The following is a description of a gene set: Comprehensive identification of all functional elements encoded in the human genome is a fundamental need in biomedical research. Here, we present a comparative analysis of the human, mouse, rat and dog genomes to create a systematic catalogue of common regulatory motifs in promoters and 3' untranslated regions (3' UTRs). The promoter analysis yields 174 candidate motifs, including most previously known transcription-factor binding sites and 105 new motifs. The 3'-UTR analysis yields 106 motifs likely to be involved in post-transcriptional regulation. Nearly one-half are associated with microRNAs (miRNAs), leading to the discovery of many new miRNA genes and their likely target genes. Our results suggest that previous estimates of the number of human miRNA genes were low, and that miRNAs regulate at least 20% of human genes. The overall results provide a systematic view of gene regulation in the human, which will be refined as additional mammalian genomes become available. from publication Xie X, Lu J, Kulbokas EJ, Golub TR, Mootha V, Lindblad-Toh K, Lander ES, Kellis M (PMID 15735639) Genes having at least one occurrence of the highly conserved motif M55 TGGAAA in the regions spanning 4 kb centered on their transcription starting sites. This matches the NFAT, NFATC transcription factor binding site V$NFAT_Q4_01 (v7.4 TRANSFAC). Human Gene Set: TGGAAA_NFAT_Q4_01 studied in species Homo sapiens, and this is the list of marker genes: BMP2K, SMAD5, MRPL37, MYL3, ZMYND8, UBE2U, DNAH12, DAB1, TIMM9, FASTKD2, BAAT, ANGPTL2, RAB6A, ANKHD1-EIF4EBP3, RCAN2, UTP18, C3orf49, LYG2, LIF, RNF43, TSPAN2, LRATD2, PIM2, CAMKV, CORT, C6orf62, TLX3, PLEKHN1, NEDD4L, C8orf34 (chromosome 8 open reading frame 34), GLS, CRAT, HOXD3 (NCBI Gene Id 3232), SLC25A13, STARD13 (NCBI Gene Id 90627), HS6ST2, SKP2, ARID1B, ARRDC4, TJP2, PPARGC1A, SPRED1, FERD3L, PITPNC1 (phosphatidylinositol transfer protein cytoplasmic 1), GAS2, ZBTB5, MTF1, DAAM2, KMT2D, ENPP2, SPRY2, AMD1, IL1RN, WBP2NL, GPR22, GCNT2, STIP1, QTRT2, DHX40, DIAPH1, ATXN1, CDK11B, SFTPD, ETV5, DIS3L2, EPN1, BZW2, VAX1, WNK4, CITED2, LAP3, PPP2R3A, EFHD1, SOX14, MXI1, S1PR2, CFAP53, LDHAL6B, AKR1B1, DYNLL1 (dynein light chain LC8-type 1), FLVCR2, LRRTM4, IL2, SEPTIN9, EDA, TNFSF10, PTPRZ1, STAG1, HGF, SLITRK3, NHERF1, TMEM117, ANGPT1 (NCBI Gene Id 284), TNXB, HOXD8, IL7R, UBE2O, AMBN, TYR, GABRR1, TOB2, IFNG, CREM, MLIP, VAMP3, ZFAND3, MGAT4B, HS3ST3B1, KCNN2, FCRL2, GPR107 (G protein-coupled receptor 107), KCNJ2, CCDC191, LURAP1L, PPP1R1B, DAW1, KRT8P41, RPL23A, TMPRSS2, LTBP2, ADD3, GPR158, SERPINI2, BNC2, NSUN4, ASPH, MBNL2, HDAC6, LAG3, SOX2, RBMX, GASAL1, ADGRV1, LIMS1, SAG, ADAM9, ADORA1, TLL1, MTX1, SVIL, TMEM108, ESPN, RUNX1T1, FGF8, PHF21A, VEGFA, PPP1R10, VN1R3, TUBA1A, ANKRD28, MXRA8, RBM14, MRC2, MRPL28, POU2F3, NNAT, OTX1, RNF6 (NCBI Gene Id 6049), ISYNA1, FARS2, PHF6, SLITRK1, MRGPRF, SH2D2A, VPS37B, WNT5A, HSD17B12, KIRREL2, TSC22D3, CDH5, PAX3, POU2AF1, ZNF431, FAM241A, EOMES, ARCN1, NUAK2, CD40LG, DDX3Y, TFAP2D, DDR2, PPARA, IL4, ACMSD, TCEAL7, MARCHF5, ATP6V1G1, FAM107B, SRPX, NTF3, ZBTB10, GRWD1, MIR137HG, DTNA, ZNF532, PDLIM3, SSBP2, NPEPPS, SLC16A11, JAG1, HOXA5, RUNDC1, ATP1B4, ADAM12, ZNF502, CEP120, APOD, NFATC2, SREK1, EPC1, RELCH, TNFRSF11B (NCBI Gene Id 4982), TRDMT1, IKZF2, CFAP47, EBF2, MTBP, MYO19, PRKAG2, SPATA31H1, RWDD3, GREB1, XPOT, RAB11A, GPR42, GDNF, ANKRD42, CAB39L, MOBP, RASGEF1A, AQP4-AS1, SMPDL3A, GRM3, KRTAP17-1 (NCBI Gene Id 83902), MCF2, ADAMTSL3, NCKAP5, USP32 (NCBI Gene Id 84669), MAP3K8, PPP2R5D, NFATC4, ARHGEF12, FCRLA, PCF11, ARHGAP29, ZC3H10, GDA, IGF1, UBQLNL, PDK2, HYAL3, EIF4H, CALHM2, EYA1, PDK3, CLEC1A, ENPP3, RASGRF2 (NCBI Gene Id 89993), PAX6, LMO3, SOAT1, SMPD3, EIF3D, RACGAP1, WWP2, SIK2 (salt inducible kinase 2), FSTL5, HOXA11, RTL10 (NCBI Gene Id 79680), S100PBP, SPP1, LLCFC1, NMNAT2, HPX, A1CF, ZEB2, HCAR1, TAC1, EIF3J, ZNF711, TCF4, KCND3, TPI1, SRSF6, RGS1, PELI2, ZIC1, PITX3, RARB, DCLK1, DICER1, PIGB, LAMB3, NSG2, CCN1, ZIC4, EGFL6, AGO3, USPL1, GDPD5, AP1G1, LIX1L, GAS7, PKP4, UBE2E1, GFOD1, IL23A, NFIA, HHATL, PSMA1, NAA50, DEF6, RPA3, ZNF354C, BTBD10, UCK2, MME, MIR17HG, ZNF563, MAPK10, WNT1, CCNI, TECTA, SMC1A, ERBB3, RALYL, FUZ, ELK3, CCDC14, SRCAP, OSCAR, EHMT2, KANK4, ABRA, TFAP4, CLCN3, PCDH20, NUP210L, ZFAT, RCOR1, MRTFA, ABR, EMILIN3, CEP41, FLJ40288, SERPINC1 (NCBI Gene Id 462), SFPQ, ELMOD1, FAM170A (NCBI Gene Id 340069), TRMT9B, CNIH1, MAB21L2, XPNPEP1, SPINT1, RBFOX2, F9, CARTPT, STOML2, SLC6A12, BARHL1, TASOR, PRMT5, CPE, HNRNPC, DAAM1, FAM120C, TNFRSF19, COLEC12, BEND7, GDF10, ANKRD36B, IDH3B, TSPAN5, CNOT8, ANKHD1, SDHC, CNTNAP2, SMTNL2, CRISP1, TRIM46, PSMB5, TNS1, CPA2, RIPOR2, GADD45A, SOS1, PACSIN3, MRPS6, ARL6IP5, HNRNPH3, FLRT3, SCUBE3, DCUN1D4, MAP4K2, DCDC1, EN1, CHN1, SOX10, CCDC80, TM2D2, GNAO1, FZD7, SDC4, CDC5L, DIPK2B, FGF10, RBM39, ENSG00000291228, EIF4G1, EPYC, FXYD6, HNF1B, SIX3, DZANK1, RESF1, NKX2-2, BDNF, BTBD9, R3HDM2, IL2RG, RIT1, ATP2B1, ACE2, AP3D1, IL6, LRRC75A, JADE1, NCL, IL17RB, ZNF143, FGF12, BICDL1, RARA, PLAGL2, SHANK2, RREB1, NUMB, CCDC6, VSNL1, SRFBP1, CNTF, CD86, BCL2L14, ADAMTS2, KRT14, MECOM, SORBS3, HOXC4, SV2A, DCLK2, ZNF710, KIF21A, TAFA1, ANKRD20A19P, ATG2B, NFAT5, RHEBL1 (NCBI Gene Id 121268), PAQR5, DMP1, KLHL4, RUSC1-AS1, TIAM1, OMA1, NREP, ZNF521, CCDC148, CCDC3, HS1BP3, REPIN1, TNFSF11, EVA1A, NIM1K, TREX1, HNRNPF, CCNC, PRCC, CORO1C, FLNC, KLF12, NOL4L, XPNPEP2, LINC00671, TNFAIP8, CDC42EP3, C16orf74, TAL1, NR3C2, PER2, C22orf31, ACO1, IFT20, WDR5B, MAP2K3, FAM110D, MYF5, PDP1, FSTL1, PLAC1, PNOC, SCN3A, RRBP1, TSHZ2, NAA38, IQCB1, GABPB2 (NCBI Gene Id 126626), WNK1, CFAP161, CACNB1, CTLA4, GPHB5, HOXC11, LEP, CRK, PRKD2, TSSK3, PFDN1, LINC02363, HOXB7, POU3F4, NSD2, LYZL4, RAPGEF6, GATA3, SEMA4C, DNAJB7, TACC2, ACYP2, CREB5, KCNH5, STXBP1, NDUFS4, CILP, ZNF445, IMPA2, EGF, RNF128, HOXA1, ST8SIA4, TCF12, HOXB1, CYFIP2, HSD3B7, NR1D1, FAM117A (NCBI Gene Id 81558), JDP2, SOBP, NONO, CSRP3, RABL6, VWA1, ARMCX6, NDRG2 (NDRG family member 2), TAC4, KLF8, GMIP, LRRN4CL, LGSN, TADA2A, SLK, HCFC1R1, CCDC91, COPS3, PRKACA, TMBIM6, EAF2, NOTUM, RORA, RPL41, WRAP53, CYB5D1 (NCBI Gene Id 124637), SLC35A2, NCDN, RAB30, C3orf62, HSPH1, SOX11, NDUFB9, NRIP2, HAO2 (NCBI Gene Id 51544), ABCD2, STRIP1, CIMIP6, CLEC11A, TP53BP1, HOXA13, ABHD5, RASGRP3, HOXB2, C4orf36, OPCML, ANGPTL7, SLC43A2 (NCBI Gene Id 124935), CCDC18, LSAMP, FOXD3, PLCL1, CNIH4, OLFML3, ALS2CL, FHDC1, DONSON, SORT1, CAD, TBX5, ZFAND5, SMARCA2, IL17B, UBL3, DLL4, GKN2, ABLIM2, GCAT, LINC00303, NRGN (neurogranin), UCN3, SNX15, DHX37, ZBTB18, MDH1, NIN, RCAN1, CACNA1C, TRERF1, ZZEF1, CSPG4, ENPP1, HIVEP1, SLC44A3, INSRR, DCUN1D3, ETNK2, NRG1, EMP1, HAUS3, MEIOB, LINC00305, KRTCAP2, HOXA9, FTH1, BTG1, GPR135, RUNX1, CAVIN1, MEPCE, RNF19A, VCAN, PCDHA11, ITGA2, ESR1, CFAP57, MAGIX (MAGI family member, X-linked), SYNRG, PID1, PODN, CACNB2, TRIT1, ACKR4, ITGB1BP2, NEDD4, ZNF282, CHD2, CHCHD7, VPS11, LMO2, IL16, TBL1X, FBXL14, GAD1, DOCK8-AS1, CALM1, SACM1L, LDB2, VIT, GATA6, BMP2, STN1, PRSS12, NR5A2, SOHLH2, DDC, MAPK6, MIER3, BMP5, KCNJ10, PCDHA13, GAPT, PCSK7, GABRE (gamma-aminobutyric acid type A receptor subunit epsilon), FXYD2, GALNT7, IP6K2, TRIB2, ZNF593, TAFAZZIN, GABRB3, MAP4K4, LRP6, PDGFB, GLS2, MRPS18B (mitochondrial ribosomal protein S18B), PRKCH, PPM1K, S100A8 (NCBI Gene Id 6279), HTRA4 (NCBI Gene Id 203100), CISH, ANXA10, SOX3, PCDHGC3, CAPN6, TMEM164, UBE2B, NOS1, LOX (NCBI Gene Id 4015), MTIF2, PDE1B, WASL (NCBI Gene Id 8976), KCNA5, ADAMTS4, KCNJ8, LINC00898, C12orf50 (NCBI Gene Id 160419), DYNLT5, DOC2B, GTF2E2, CMSS1, SH3KBP1, DCHS2, JMJD1C, MAN1A2, STX16, PLOD2, GNAQ, SLC25A4, TEC, CPNE1, CASK, COL16A1, SLC39A7, APOM, GIGYF2, PIGN, CSAD, MTSS1, JADE2, RBM12B, AGTR2, GTPBP1, EIF1, PRELP, ABRAXAS2 (NCBI Gene Id 96567), IL12B, GPSM2, DIO2, PPM1D, BMI1, ZDHHC18, ZNFX1, NFKBID, MECP2, CADM2, TNFAIP1 (TNF alpha induced protein 1), STAC2, ZIC5, MCC, POU4F3, IFT22, OTUD5, PYGB, WFIKKN2, NAPG, GPR173, NDP, DCN, PSME3IP1, LMOD1, SRPK2, RABGAP1L, CHRNB3, SERPINH1, ZNF436, USP12, CNTD1, ALG6, VCP, SLC30A7, SLC7A8, LHX1, PHACTR3, HDDC3, PHTF1, KCNQ5, HAS2, PABIR3, TBL1Y, YWHAQ, RASSF2, ZNF654, SEMA7A, LGALS1, OFCC1, ZNF547, MAP7, KIAA0825, SLC17A6, ID4, SENP1, ERRFI1, UBALD2, SERPIND1, PPP2R1B, AQP2, ZFHX3, XBP1, WDR81, ADCY2, CDKN1A, PLPPR1, PICALM, NEURL1, BOK, GYPC, COL1A2, POGK, SNCAIP, BSN, PRPF38B, RTL3, SPAG9, VIM, CHM, UGT1A6, XYLT2, SIAE, PRRT1, GPER1, FCHSD1, CRTAC1, LINC00649, NFATC1, MAB21L3, HNF4G, SATB2, WIPF1, LIMK2, ATP1A2, PNLIP, GAL3ST3, CRIPT, ATP1B1 (NCBI Gene Id 481), MYO1E, RBMS2, SEPHS2, BMX, C1RL, ST6GALNAC3, RAB8B, PDLIM5, ATP2B4, EMX1, FBXL19-AS1, XPO1, KCNA1, ELAVL3, PDE4B, STAT3, CLVS1, NDUFC1, SFMBT1, NALF2, ZNF296, KIRREL3, KCNJ13, ZNF800, CDH6, EDNRA, COL12A1, SNX25, TINF2 (NCBI Gene Id 26277), REST, CTBS, TGFB2, KYNU, PUM3, NR4A1, MED26, LRRTM3, TBX3, FAP, DLG2, HOXA10, MMP14, DBN1, NUDT2, SEMA3A, ESRRB, KLF7, CNTN5, HOXD10, CHDH, RASGRP4 (RAS guanyl releasing protein 4), SRC, CALCR, IL9, AEBP2, KCNQ4, GNAS, NDST4, TNPO1, NR4A2, CD79B, YAP1, GNGT2, TRIM25, TGIF1, VEGFB, CRCT1 (NCBI Gene Id 54544), C21orf91, NEK10, CTTNBP2NL, SLA, DSG3, DNHD1, SPATS2, IL1RAPL1, SBF2 (NCBI Gene Id 81846), CCL5, KCNJ14, PSMA8, ILDR1, IL6ST, PLCB1, NOB1, FHL3, WARS1, NR4A3, DOCK3, DNMT3B, C1S, CTHRC1, IRS2, TWIST1, CYP26B1, PYM1, TECR, REEP6, GLRA2, TSEN34, EBNA1BP2, NAV3, ARRDC3, GAP43, SCAMP1, SPMIP6, PEX1, ZMYM4, AMPH, CD74, PAGE4, DEPDC7, FABP2, NMB, GDAP1, PIGW, ZMIZ1, WNT9B, NGF, CELF4, HDAC4, SLC16A6, ASPN, SHOX2, YARS1, VAMP8, DDX17, DLX1, TRPS1, RALY, HEPACAM, BPIFA1, MLF1 (NCBI Gene Id 4291), FBL, ITGB8, RPS10, EDC4 (enhancer of mRNA decapping 4), LRP2BP, SERPINB10 (NCBI Gene Id 5273), AGBL1, SFRP4, ECEL1, ZNF430, SLC9A7 (NCBI Gene Id 84679), KMT2C, KLF5, NFIB, GIMAP1, SGCD, HOXA2, ACSS1, CLCA3P, ACLY, VPS13B, LRRTM1, ZBTB32, STX4, TMEM97, CDK2AP1, LSM6, FXR2, ZNF138, ESYT2, SYTL4, C6orf47, LOXL1, IL22, SOX21, ARHGAP18, LRP1B, STARD4, TBC1D8B, GPANK1, DTX3, PHEX, KLHL9 (NCBI Gene Id 55958), KATNA1, FCAMR, NT5C2, PPM1B, OSTN, ZNF396, RTKN, SLC16A1, PIGF, ACKR3, CD72, FFAR2, SELENOI, TMPRSS11F, IFRD1, RBM48, ATP6V1A, IL25, MYO1C (myosin IC), ABL1, FFAR3, TTLL6, LRRC2, RCC2, FHL5, KLF14, PPP2R5E, NSRP1, C1QL1, TRARG1, GRK5, SENP8 (NCBI Gene Id 123228), ID2, DLGAP4, ZNF768, LRRFIP1, DNAJA1, NXF4, TMEM187, TMEM9B (TMEM9 domain family member B), CCDC140, HAND2, STK26, MGP, PPFIA2, FN1, TRIM8, PTK7, GRIN1, SCN2B, ATXN10, POU4F1, AQP4, PDE4D, ATXN7L1, DPYSL2, APMAP, FST, FCER1G, KRIT1, ARHGEF2, CREBZF, ASIC2, NUP155, SERTAD4, CDKL2, BEX3, UBE2H, ARHGEF25, FGF6, ADM, DES, DPH1, RASL12, ADAMTS14, C17orf50, HAND1, INS, ITIH3, HSPA4L, DEAF1, GPR85, IQGAP3, TAGAP, WWOX (WW domain containing oxidoreductase), SEMA6D, TNF, CTSK, PVALB, SLC38A2, KIAA1549L, MEF2C, PRDM1, CALD1, NFKBIA, BCL11A, C9orf72, PRG4, JPT2, UNC5C, GUCY1B1, SPAG6, KRT17, ATP2C1, MIR22HG, NAP1L5, FUT7, IGFBP7, AOC2, CUL3, PTGER1, BMP6, STC1, COX4I2, C1orf21, TEAD1, DPF2, ELF5, SLN, HOXA4, MMP3, ABCB7, HS6ST3, ARHGAP8, FGF14 (NCBI Gene Id 317685), RNF220, KERA, PTPRA, RBMS3, COPZ1, STX7, POFUT1, ENSG00000204117, PCDH10, FGF16, PCSK6, AIG1, DPF3, CHST11, CPEB3, HESX1, SMC2, HECTD2, CPLANE2, ALYREF, PHKA1, CALB1, RFTN2, KLF11, ATP1B3, SEPTIN7, ANAPC11, IRX5, RNF152, KIAA0586, PTGER2, NFIL3 (NCBI Gene Id 4783), CDK6 (cyclin dependent kinase 6), CYP2D6, C1QTNF3, GLA, KBTBD12, HYAL2, THBS3, NECTIN1, SPP2, HMGA2, CTAGE4, TENT5A, RARG, ITGA7, IL23R, HTR7, AP4S1, COL2A1, PCBP2, ICAM1, TNFRSF8, ZFP36L1, EHD4, MEIS1, RNF133, SP1, DAB2 (NCBI Gene Id 1601), SCG2, AJUBA, ATP5MK, SMARCE1, FOS, ACAP1, SNX12, EGFLAM, NRN1L, HMGCR, EXD2, RELA, ESRRG, PGRMC2, TGFB3, PCDH12, MARCKSL1, PGAM1, MYH1, GSN, ITPR1, CACNG2, CSNK2B, POGZ, C8orf82, COTL1, ST8SIA1, ZNF277, HIGD1B, CPEB4, HIGD1A, FNDC9, FOXP3, MFSD14A, SGK1, ELAVL4, DGKG, TSHB, GPR150, MSMB, SLC7A1, TYMP, PTP4A2, NOG, OPHN1, ARL5A, THOC6, SOX5, CLDN17, TFE3, OMD, RASAL2, SAYSD1, RETN, OGT, PTOV1, BHLHE40, HAPLN1, NF1, PIK3IP1, TNFRSF1A, LTC4S, MAGEH1, NPAS2, MAPK4, LDHB, TBX20, ARMCX4, SOX9, LGALSL, S100A10, CFAP70, GRB10, MTX2, SYNC, MAFF, AIFM1, OVOL1, TFDP2 (NCBI Gene Id 7029), GLDN, PRF1, TMEM125, PLXNB1, MAN1C1, PPP4R4, SULF1, PAX1, CMTM6, SYT4, FUT11, MYO9A, CNIH2 (NCBI Gene Id 254263), SLITRK5, DCTN4, PDXDC2P-NPIPB14P, VGLL3, SDCBP, DNTT, TEX15, PCDHA6, H2BC21, MTMR11, SSTR5, VAC14, PLEC, IL5 (interleukin 5), BRINP3, HSD11B1, ELMO1, CASKIN2, SMURF2, NTNG2, NKAIN3, OLFML1, KMT2A, COL4A6, MAN1A1, TULP1, PAK3, MAML3, ACBD3, APOBEC2, UBE2W, AGPAT4, CCDC171, TUBB6, DUSP7, PCNX1, KCNMA1, DGKZ, CCN2, KMT5B, SNAP25, IGSF3, FLOT1, ALPK2, PBXIP1, FBXW7, ZNF124, APOLD1, EXTL2, CCL4, RAP2C, ZNF91, NDUFA3, MDFIC, USP25, PAMR1, BCL9, BCAR3, CDIN1, IL11, USP2, ALKBH6, TTLL7, UHMK1, EFNB3, LTF, PPAN, CD200R1, PDK4, EBP, AUTS2, PFN2, ETS2, GPR162, IL22RA1, HEBP2, GPAT3, C6orf136, STRN3, WASF1, KIRREL3-AS3, CCL2, APLP2, LDB3, SPTBN1, ELF4 (NCBI Gene Id 2000), CAMK2G, CNN1, CCIN, NAALADL2, ATP2A2, SPTLC3, GARRE1, DOCK4, CEP70, NOL4, IL20RB, PRR11, RILPL2, ANTXR1, TNFRSF1B, ZNF429, RBFOX1, VAMP5, RGL2, TGIF2, MIDEAS, CTNND2, SYNE2, HLA-B, MCOLN3, LINC02915, SIX6, DCAF11, C1orf116, TPM1, ANGPTL1, PHGDH, PCDH8, QRFP, FMR1, GREM1, FAM43B, CDK8, C1GALT1C1, SSTR5-AS1, IL11RA, BAIAP3, CDH16, HOXC5, THAP9, RBKS, SCN2A, ZNF384, ARMC12, KCNA2, PRRX1, HAGH, GADD45B, FYB1, ASB11, NCOA3, HIC2, ITGA8, MORF4L2, ZNF385A, PPP2CA, DOCK9, ADAMTS17, MSH5, OR2C1, SMYD2, UBASH3B, CELF3, CHST9, ABI3, IPCEF1, RGS3, CACNB3, OR6C3, KCNJ1, PKP3, MYCLP1, GABRA6, B4GALT5, ASPA, MOSPD2, SH3BGRL2, ALDH1A1, SEMA6A, POU3F3, FOXG1, MEOX2, VRK1, GNB1L, BBS4, TPM3, KCTD6, CNR1, NINJ2, SKA2, EBF1, CDK11A, TRA2A, ATP6V1F, INO80D, MCAM (NCBI Gene Id 4162), HSPG2, CACUL1, NRAS (NRAS proto-oncogene, GTPase), FRMD6 (FERM domain containing 6), ETS1, VPS45, EPCIP, SERPINI1, EXT1, LYRM1, MAML2, TCTA, RBBP7, OTUD7B, PTGDS, FGL1, CAST, PSMC3IP, NANOS1, MBOAT7, VANGL1, USP5, TMEM163, SCP2D1, LSM12, ATP5MC1, ZFP2, RANBP3L, WDR44, CTNND1, DNAAF11, FASLG, FIBIN (fin bud initiation factor homolog), PDZRN4, RAX, TBC1D8 (TBC1 domain family member 8), SEMA4D, KRT25, TRPV1, NFIX, RAP2B, APBA1, SUPT16H, PSIP1, RND2, H2AC20, YRDC (yrdC N6-threonylcarbamoyltransferase domain containing), FAM76B, RHOA, HMGN3, YPEL5, USP36, E2F3, SIPA1, ZNF407, CCDC71, COLQ, RSPRY1, HOXB4, PDCD4, UCKL1, N4BP1, ARID4A, WDR27, ZNF827, MID2, ZC3H13, COL27A1, RIN1, DMD, WNT3, GPX1 (glutathione peroxidase 1), CACNA2D3 (NCBI Gene Id 55799), ITM2C, IGFBP5, EML4, MIR9-1HG, ISG15, WAC (NCBI Gene Id 55468), CHL1 (cell adhesion molecule L1 like, NCBI Gene Id 10752), PPP1R13B, MAB21L1, KCNJ5, ANKMY2, NKX6-1, KCNIP2, ZNF622, STMN2, BCL9L, DLC1, HNRNPD, KLHL41, PHLDB1, ZNF516-DT, TMEM81, SALL3, TFAP2B, UCHL1, FLI1, PROK2, ATP5PD, NUFIP2, FOXB1, PDE3B, CXCR5, XKRX, H2AC21, AKTIP, FBXL19, NR1I3, ARHGAP44, IL13, CALU, INPP5F, BCAP31, EIF2B5, GFI1, STMN1, RNF41, ABCD1, RPL13, MCU, MC5R, RAD23A, CTDSPL2, TMC1, SMIM43, VWA2, SASH1, LINC01597, POLG2, FBXO11, POLR2C, FOXP2, TBXAS1, ACACA, GADL1, NAA80, DIS3L, IL18R1, LRRN3, MRPL13, VGF, PLAG1 (PLAG1 zinc finger), ZBTB37, HOMER1, GRHL3, CFAP68, TMTC2, SPA17, HOXA7, RGS2, PPT2, TEX26, RAI2, ADAMTSL1, GABARAP, CD27, SLC43A1, BHLHE22, SYT10, TP53, STARD10, PCMTD1, NAB2, JAKMIP1, TBX2, KLHL13, BRCA2, GRM8, RERE, LMO4, RASEF (RAS and EF-hand domain containing), SPRY1, TMEM35A, PGS1, ASB5, TPM2, BLCAP, FOXP1, CDK9, SERPINB7, CUEDC1, TUB, KRTAP21-2, LINC01567, DSTN, RAB3IP, MIB1, FOXO4, AMOTL1, PDCD6, HNRNPH2, C1orf122, SERINC5, PPFIBP1, MITF, GRIA3, TMEM37, DDX3X, ARHGAP6, AREG, HOXA3, UPP2, WNT4, ATRNL1, H1-0, PTGES, HOXD4, IRX6, RBM26, TMEM62 (transmembrane protein 62), ADCY10, MLH3, USP40, KCNH7, DKK2, PDZD2, IBSP, SGIP1, NXNL2, ENSA, RXRB, NFKB2, CALCRL, RNF38, SOSTDC1, FMOD, COL8A1, NLK, NR6A1, PTCHD1, UBD, PRR34, GPR119, MARVELD2, NTM-AS1, HDHD3, DGKA, UTP14A, DNAJC13, CABLES1, RHOB, SHC1, HIF1A, PIK3R3, CKS1B, LINC02880, FOXE3, CREB1, AARSD1, JARID2, SLC4A3, KRTAP4-1, FANK1, KRT32, RDH11, BCL6, CTAG2, ERBB4, ADAMTSL4, UNC79, CCNT2 (NCBI Gene Id 905), PDE4C, SMPD1, PHOX2B, ARIH2, DIDO1, AFF3, RORC, ZNF420, TRDN, HCN1, IER3, NSUN6, GSTA4, ARAP3 (NCBI Gene Id 64411), ZKSCAN8, ORAI3, UBR5, MICU2, SLC27A3, TINAGL1, FAM81A (NCBI Gene Id 145773), RPS6KA3, SOCS2, CXCL10, MANF, SLC25A12, H3-3A, FOXF2, KSR2, DHH, BTBD3, CD68, EXO1, MREG, BMPR2, SKIDA1, BLMH, SCRN3, TMEM216 (transmembrane protein 216), LCA5, PTPRO, ZNF232, UQCRFS1, C2CD2L (NCBI Gene Id 9854), PEX16, BABAM2, ORAI2, SYNCRIP, LDLRAD4, RAB38, MBNL1, POMC, RIBC1, SCNN1A, TAB2, ANP32A, WBP4, NUDT3, RNF182, ANKS6, TBCD, FTHL17, STEAP2, SH2B3, CLDN19, FAM110A, ZNF675, CHODL, PMP22, TRIM37, HOXB6, ARHGAP20, LTBP1, TBX4, KLF13, ZNF436-AS1, TCTN3, MAP1B, DHRS3, FGD4, PIM1, IL17F, TNNT3, DR1, ZNF644, FGF17, MAP4K3, GNL3LP1 (G protein nucleolar 3 like pseudogene 1), FAHD1, SPATA8, RCN3, AKT3, GABRQ, PAK1IP1, NECAP1, LUZP1, CCL28, RIN2, WBP1, DNASE2B, SLIT3, ENOX1, PTCH1, EHBP1, TJAP1, CADM1, IRF4, KCNE2, NRDC, PRKCG, CLCN2, TMEM126B, IL21, FANCB, IGFBP3, FGF13, BMP4, PITX2, KHDRBS2, SLC26A7, TRPM3, DDIT4L, LPL, MED13, CDCP2 (NCBI Gene Id 343190), PNKD, PPP4R2, SNX2, CD82, LINC02873, TATDN1, CDK17, NDUFS2, TMEFF1, MLLT3, CDH20, KRTAP11-1, TSGA10, NR3C1 (NCBI Gene Id 389335), SLC2A12, SLC25A37, CCDC178, CCDC141, ANKRD35, ZNF485, MIEF1, FGF7, SPINK5, BCOR, RAB7A, UPF2 (UPF2 regulator of nonsense mediated mRNA decay), ADCY4, TEDC1, LPIN2, CYB5D2, COA3, LRP5, GPR101, NTRK1, KATNAL2, MYH8, SEPTIN4, VEGFC, TRPC4AP, RASSF8 (Ras association domain family member 8), KAT14, SND1, HSPB7, NPR3, UBR3 (ubiquitin protein ligase E3 component n-recognin 3), HTR1F, EGR2, IFT43, CLDN15, MRPL45, LINC00314, ZIC2, YME1L1, VGLL4 (NCBI Gene Id 9686), PCSK5, TNKS1BP1, MYH2, PDGFRA, ETV1, INHBA, RBM4, NPHP4